Given this list of marker genes ABHD17A, CPT1C, LYPLA1, DESI1, PPT1, DESI2, ABHD17C, ABHD17B, PPT2, LYPLA2, ABHD13, LYPLAL1, ABHD10, ABHD12, here is a description of the gene set: Catalysis of the reaction: palmitoyl-protein + H2O = palmitate + protein. Human Gene Set: GOMF_PALMITOYL_PROTEIN_HYDROLASE_ACTIVITY species: Homo sapiens